Given this list of marker genes TNFRSF10D, TNFRSF10B (TNF receptor superfamily member 10b), TNFRSF10C, TNFRSF10A, TNFSF10, here is a description of the gene set: Binding to TRAIL (TNF-related apoptosis inducing ligand), a member of the tumor necrosis factor ligand family that rapidly induces apoptosis in a variety of transformed cell lines. studied in species Homo sapiens Human Gene Set: GOMF_TRAIL_BINDING